The following is a description of a gene set: Genes down-regulated in primary bronchial epithelial cells stimulated with: IL17A versus IL17A and IL22. from publication Aujla SJ, Chan YR, Zheng M, Fei M, Askew DJ, Pociask DA, Reinhart TA, McAllister F, Edeal J, Gaus K, Husain S, Kreindler JL, Dubin PJ, Pilewski JM, Myerburg MM, Mason CA, Iwakura Y, Kolls JK (PMID 18264110) Human Gene Set: GSE10240_IL17_VS_IL17_AND_IL22_STIM_PRIMARY_BRONCHIAL_EPITHELIAL_CELLS_DN species: Homo sapiens Primary HBE cells were stimulated with IL-22 and IL-17, and gene expression was studied using an Affymetrix platform microarray, in order to investigate which genes may be upregulated or downregulated in response to these cytokines. Of particular interest was the host defense genes such as antimicrobial peptides, which have been shown to be upregulated by IL-22 and IL-17 in skin keratinocytes., and this is the list of marker genes: UBE4B, FETUB, SLFN13, TNFRSF21, CCDC138, SMCO2, SMARCC2, PDE8B, CBFA2T3, SLC7A7, FAM13C, ABCA3, RAB38, IGF2BP1, TBC1D24, CHST15, FAM167A, THSD1, MLH1, SCN8A, APC2, C5orf46, AMTN, ENG, HGH1 (HGH1 homolog), SCAP, B3GNT2, ARHGAP35, KLHDC10, CASKIN2, ELP2, BTRC, GPATCH4, ARHGEF10, TRPC7, DLG3, LPAR2, GADD45A, ABL2, FAM234B, MIOX, PTOV1, CISH, RBM6, LRCH2, ZEB1, TBCEL, PLEKHA7, RSPO4, SLC22A3, CYB561, PKN3, RSAD2, DYNC2H1, INSR, RASSF9, SDC4, ESR1, PAK4, HBEGF, NLGN3 (NCBI Gene Id 54413), PCBP2 (NCBI Gene Id 5094), TET1, KIF21A, TACR2, ABI2, RTL6, LAYN, DSEL, CARMIL1, TMPRSS4, LRRIQ3, TBC1D9, BAIAP2L1, CA3, C11orf65, PRCC, MED1, KRT18, KCNJ5, MYH1, DCLK2, PDS5B, TIMELESS, PLSCR3, OSBP, TMPRSS3, RBMX2, RBP7, TSPAN2, RHOBTB3, ATXN7L3B, CTNND2, TBXA2R, OSBPL1A, LMTK3, MUC13, BRD3, UCHL1, ZC3HAV1L, PLCL1, DLG4, FPGS, GRK3, LUC7L, MTSS1, FMNL2, MAPKAPK3, LONRF1, HEMK1, SLIT3 (NCBI Gene Id 6586), TSPAN33, AQP9, TLE1, MAP3K20, TMEM98, RESP18, EPHA2, CCDC162P, PLD6, MYLK3, MGAT1, CPNE2 (copine 2), PKIG, OAZ3, CKAP4, TBX15, SCARB1, GTF2IRD1, CD79A, DNASE2, TRIM54 (tripartite motif containing 54), DAPK1, PROP1, SLC1A5, IL5, PALM, SEZ6L, ZC3H12C, RBP2, IFT81, CCAR2, CTDSPL, RAPGEFL1, SORT1, PHF12, PSD3, TCF4, CCDC57, KDF1, SLC29A3, MGST2, HLCS, PECR (peroxisomal trans-2-enoyl-CoA reductase), PRCP, RYR1, LARS2, BMF, ZNF428, LGI3, PIK3R4, KLF1, R3HDM1, DNAJC21, P2RY2, CEP97, TBC1D31, TBL1XR1, ZNF667, CAMKV, PPM1L, VPREB3, HDAC9, MTOR, MRM1, KCNJ2, NEUROD4, FOXRED2, SRSF6, MAP4K3, TXNRD3, PLA2G7, NLRP3, IGLL1, HNF4A, CUX1, RENBP, GNG8, TNFRSF17, SV2B, IL7R, TMEM191C, KAZALD1, CNFN, IFT122, SLC43A2, FAM53A, ATXN2, HOXB13